The following is a description of a gene set: A functional anomaly of the knee joint. Abnormal knee physiology species: Homo sapiens Human Gene Set: HP_ABNORMAL_KNEE_PHYSIOLOGY, and this is the list of marker genes: MCOLN1, XYLT1, DPYSL5, LMX1B, CSGALNACT1, COL1A1, KRAS, MEFV, SH3PXD2B, ECEL1, CDT1, GABRG2 (gamma-aminobutyric acid type A receptor subunit gamma2), DYM, HGD, FGFR3, SLC10A7, FBN1, FGD1, COL9A3, AEBP1, ASCC3, FILIP1, SLC6A9, AP4M1, EZH2, HRAS, GPC6, FLNB, CANT1, ELN, NRAS, SYNE1 (spectrin repeat containing nuclear envelope protein 1), HNRNPH1, GABRA1, EXT2, ALDH18A1, FBLN5, AP4B1, PRRT2, COL5A1, AP4E1, SCN2A, ATP7A, CFL2, PRR12, WASF1, TRIP11, SCN1B (sodium voltage-gated channel beta subunit 1), MAN2C1, VCP, RYR1, DYSF, ASAH1, PDGFRB, B3GAT3, ORC1, SLC35A3, SCN9A, FBN2, TNFRSF1A, GABRD, ADGRV1, AP4S1, SCN1A, BPNT2, CTDP1, PCDH19, TOR1A, FLNA, EXOC6B, MYOT, COL2A1, FGF13, GRIA3, BMP1 (NCBI Gene Id 649), B4GALT7, SKI, COL1A2, SLC35B2, COMP, MAP3K7, HCN1, IFT56, PTEN, STX1B, EXT1, ANO5, CHST3, FLNC